Given this list of marker genes Cdk5rap1, Thap11, Polr3b, Nsun4, Pde12, Sirt3 (NCBI Gene Id 69497), Polr2a, Prorp, Trit1, Rpusd4, Dars2, Fastkd1, Angel2, Mterf1a, Kat8, Mterf3, Trnt1, Grsf1, Slirp, Mettl4, Slc25a33, Gars1, Supv3l1, Polr2b, Tfb1m (NCBI Gene Id 224481), Myg1, Polr1a, Twnk, Prkaa1, Polr1b, Mto1, Mtres1, Trmt10c, Trmt5, Kansl3, Tefm, Aars2, Foxo3, Hsd17b10, Mrpl12, Pnpt1, Lrpprc, Ppargc1b, Wars2, Ears2 (glutamyl-tRNA synthetase 2, mitochondrial), Polrmt, Elac2, Mterf1b, Mterf4, Sars2, Mettl8, Yars2, Kansl1 (KAT8 regulatory NSL complex subunit 1), Mterf2, Tfb2m, Tfam, Tbrg4, here is a description of the gene set: The chemical reactions and pathways involving RNA transcribed from the mitochondrial genome and occurring in the mitochondrion. Mouse Gene Set: GOBP_MITOCHONDRIAL_RNA_METABOLIC_PROCESS species: Mus musculus